The following is a description of a gene set: from publication Yamagata T, Mathis D, Benoist C (PMID 15133507) Genes down-regulated in CD8 alphabeta HY thymocyte RTOC culture versus CD8 alphaalpha HY thymocyte RTOC culture. species: Homo sapiens Human Gene Set: GSE1112_HY_CD8AB_VS_HY_CD8AA_THYMOCYTE_RTOC_CULTURE_DN Four independent chip hybridization with RNAs from four independent RTOC cultures., and this is the list of marker genes: IRAK1, COQ2, SEC62, ATP8B4 (ATPase phospholipid transporting 8B4 (putative)), IL1B, LINC00922, XPNPEP2, IRS2 (insulin receptor substrate 2), FAM124A, RADIL, NFAT5, LTA4H, GPR68, NAPA-AS1, YRDC, SMC1B, CD55, PCTP (phosphatidylcholine transfer protein), IL1A, EMP1, GPR160, NSUN3, SAT2, TARP, FCGR1A, TLNRD1 (talin rod domain containing 1), PHC2, RBM17, YIPF6, DEFB1, HSPA4L (heat shock protein family A (Hsp70) member 4 like), SUSD3, CROCCP3, CHD5, PINK1, DNM1P46, SPTLC2, TBATA (thymus, brain and testes associated), ATP8B1, PMS2P2, HTRA1, DDX60L, RASAL3, BNIP3L, CXCL8, DUSP28, CASP1, ACVR1B, JTB, AGO3, CLEC4E, TGIF1, CCL7, EPHB1, CAPN2, ASB11, BCL2A1, CARD16, GNG12, EREG, NDUFA10, MTHFS, ING2, ARHGEF3, FAM219A, UPP1, IL24, SPARC, VSIG10L2, ERCC1, RUNX1, BCAT1, CARD6, USP3, PNP, EVA1C, TSC22D1, LRRC37A16P (NCBI Gene Id 651250), D2HGDH, SYCE2, KHNYN, LRMDA, PTPRM, USF3, KIZ, RAB4B, BNIPL, WLS, PMS2P5, CCDC71L, RHCG, PNPLA8, HOMER3, LPCAT1, LINC00954, KCNQ2, PLAUR, DBIL5P, CKAP4, ZNF551, SH3BP5, ALOX5AP, RCL1, PTGS2, LRRC8D, PROCR, MFAP3, GLIS3, RALA, TBC1D9B, SHKBP1, MAGEB3, PRAF2, TNRC6B, BCL6, TMPO, FYN, CELF1, LMO1, ADM5, RHBDF1, CXCL3, CCDC50, ZBED5, ADM, SFRP2, S100A6, F11R (NCBI Gene Id 50848), SSU72L6, SEPHS2, APOBR, IGFBP7, IL16, CAB39L, HAS1, BLOC1S1, IL22RA1, NSMAF, TSG101, EAF2, ENSG00000250685, TPST1, PRR9, TCF7L2, MPHOSPH6, HK2, RNF7, CRBN, NUDT14, TUG1, TRAIP, TRPS1, MYH7B, DENND11, METTL9, PNPLA1, RABGEF1, SERPINB2, STK17B, CDC42EP3, LCIIAR, PCDHB12, KREMEN1, ABCA1, FMNL2, FAM222B, JAKMIP2, CFAP410, PID1, PELI2 (pellino E3 ubiquitin protein ligase family member 2), MET, LY6G6E, NDRG1, GOLGA8IP, RGP1, NFKBIZ, BTN2A2, ATP2B1, C3, RCAN2, RET, TRIOBP, CCL20, LINC02877, DDIT4L, ZNF90, RBCK1, CXCL2, PPBP, DZANK1, STX3 (NCBI Gene Id 6809), SNX9, SLC19A2